The following is a description of a gene set: Mouse Gene Set: GOBP_GLYCINE_BIOSYNTHETIC_PROCESS The chemical reactions and pathways resulting in the formation of glycine, aminoethanoic acid. studied in species Mus musculus, and this is the list of marker genes: Hao1 (NCBI Gene Id 15112), Tha1, Shmt1, Shmt2, Agxt2, Agxt